Given this list of marker genes MIR548B, MIR1305, SERPINE1, MDM2, SESN3, MIR182, PTEN, MIR4491, CASP3, SIAH1, PMAIP1, BBC3, TP53, CASP8, MIR27B, CHEK2, DDB2, PERP, MIR4482, BAX, TNFRSF10B, MIR548C, ZMAT3, CYS1, TP53AIP1, SHISA5, EI24, CASP9, APAF1, ATM, BID, here is a description of the gene set: species: Homo sapiens Human Gene Set: WP_MIRNA_REGULATION_OF_P53_PATHWAY_IN_PROSTATE_CANCER miRNA regulation of p53 pathway in prostate cancer